Given this list of marker genes 1a, rep, here is a description of the gene set: studied in species Homo sapiens part of: Translation of Replicase and Assembly of the Replication Transcription Complex In a sequence of ten reactions, mature non-structural proteins (nsp) generated by cleavage of the SARS-CoV-1 pp1a / pp1ab polyproteins are assembled to form a replication – transcription complex (Fung & Liu 2019; Kirchdoerfer & Ward 2019). Reactome Pathway: Assembly of the SARS-CoV-1 Replication-Transcription Complex (RTC)